Given this list of marker genes MIR4425, STAG3, LSM4, NTRK1, TMEM147-AS1, IGHV3-63, CFAP298-TCP10L, RCOR1, HYAL3, RARA, CCR1, SECISBP2, IVL, SQSTM1, PHF21A, IRAG2, SEC14L1, TRAF4, H2BC7, GABPB2, BAZ1A-AS1, ZNF670, AP4M1, POLA2, SMAP2, ZSCAN12, MAPK14, LMNA, ZNF491, MAPKAP1, ENSG00000255476, LINC00964, ARHGAP31-AS1, RPL30P11, GEM, RC3H2, FAM167A, PPFIBP2, IFIH1, TMPO-AS1, HCG14, TVP23A, LAMTOR4, H2AC12, ANAPC11, FRA10AC1, SNHG9, CEP128, PDZD2, ZNF646, ZNF670-ZNF695, NSUN6, GPR132 (G protein-coupled receptor 132), ERCC6L2, NTN1, PARP2, MIR1245B, BRAF, RNU6-743P, ENSG00000265222, RAB4B, KMT5B, LCN15, ARID2, ANP32B, CNR1, ZNF185, IL16, APOO, ORMDL1, LINC01366, BRWD1, LIMD2, TOR1AIP1 (torsin 1A interacting protein 1), RGS9, GPD2, HELZ2, RPL17P2, ASXL1, RFFL, C12orf57, H1-5, CD69, TRNAU1AP (tRNA selenocysteine 1 associated protein 1), ITGAL, USP3-AS1, C2orf92, CD72, AFF3, TNIP2, TET3, JPH4, POLR3H, FBRS, NALT1, RILPL2 (NCBI Gene Id 196383), NAP1L1, CAB39, SLC66A2, NFKBIA, ATP6V0A1, H2BC26, REV3L, SYT17, BOD1L1, LCN10 (lipocalin 10), RNA5SP493, FUT10, MCM7, VRK1, LNPEP, ARL2BP, MAML2, LRG1, LRRC32, BATF3, FSCN1, NDE1, LZIC, TAFAZZIN, LMNB1, MYEOV, B2M, GABPB1, HMSD, ARHGEF2-AS2, RBM17, FBXW11, ANXA6, ZBTB1, RUNX1, RAD52, LDC1P, KREMEN2, CHD3, H3C4, SFT2D3, AP1G1, DDX31, TEPSIN, RNU4-38P, DOLK, SKIL, SBNO1, PPAN, ZNF295-AS1, PHF24, RIPOR2, THAP9, MIRLET7I, RELA, C16orf46, ATXN1, NIBAN3, MIR3143, ITGB1, NBN, LINC00926, CFLAR, H2AC4, LINC02392, PASK, LINC02579, STAG3L5P-PVRIG2P-PILRB, NANOS3, KLKP1, HSPA4L, CPPED1, ENO3, HMGXB4, WDR11-DT, RHOH, INTS12, RPL11, SBNO2, SHQ1, RHOXF1P3, SLC9A8, CLUAP1, ZCCHC7, RNU7-1, RAI1, BCL9L, ATM, MTMR14, LINC02157, LRP6, G6PD, MIR5700, INO80C, DENND4B, ATXN1L, LINC02100, STAR, TH2LCRR, MSI2, LINC01572, RAP2C-AS1, H2AC7, DIAPH1, H4C13, MDM2, RNVU1-19, SPATA4, RNU5B-4P, MIR27A, ARHGAP26, WRAP53, ARHGAP21, SLC39A13, NEIL2, GSK3B, RNPS1, SGPP2, DVL2, TMEM243, NDUFS7, LINC01588, PLEKHA2, PTEN, LINC00431, CYBA (cytochrome b-245 alpha chain), SEPTIN2, PPAN-P2RY11, B3GNT7, RN7SL121P, RN7SL692P (NCBI Gene Id 106479476), SNX8, GCA, LNCATV, HUWE1, TLCD1, TLNRD1, H3C11, DDHD1-DT, KDM5A, LINC02739, ASNS, RPPH1, H2AC6, LINC01719, NELFB, STRIP1, TFAP4, RBCK1, RNVU1-14, ZC3H12A, CYB561, MYO1C, SNX11, TLR1, MSC-AS1, LINC02174, FCER2, CDKL3, TNFRSF10C, ZNF417, CD70, ECE1, PRPF40B, WNT1, LCOR, ANKRD33B, HORMAD2, MIR497HG, TFEB, LINC00511, ZEB1 (NCBI Gene Id 6935), NEAT1, TRIM13, LINC02090, TG, DOCK2, LINC00384, BIRC3, TMEM248, JUN-DT, PELO, SSTR5-AS1, CTNNB1, CYS1, GABPB1-AS1, TECR, CD58, HSP90AB1, CCDC88A, CALM3, B4GALT6, LACTB, FSD1L, IMMP1LP1, H2BC10, ARSB, KLHL5, IL7R, RABEP1, ADAMTSL4-AS1, RPL10P14, HSPE1-MOB4, STX11, ASMTL, PIK3C2B, SLC12A2-DT, ZNF737, LOXL3, ZNF692, SSBP2, ADGRD1, WDR11, PARP8, PPCDC, USPL1, TNF, H2BC12, ATF4, LINC02611, NOP14-AS1, DUSP2, UNKL, SCARNA2, UBALD2, BCL6B, BTBD19, MMP9, SMIM36, CCDC88C, BAIAP2L1, ISG20, PRKCH, TSGA10 (testis specific 10), LSP1, RPS26, ZNF668, TRAJ47, REL, LINC02960, CD55, CD36, KDM2B, PAFAH2, IKZF2, H4C6, NDUFB7, POLD1, RSL24D1P11, SLC25A11, MEF2C, AMZ2P1, RNU2-63P, ADAM7-AS1, COA1, IKZF1, VRTN, LOXL2-AS1, KLLN, UBE2B, MAK, ENSG00000255491, SYNGR2, GSK3B-DT, PSMA1, SIRT2, GARNL3, TRIP12, ZNF581, ZBTB25, NUP107-DT, ENSG00000273727, MCL1, MYO1G, RNU4-2, CFAP298, H2BC21, APLF, CASC15, CD83, C20orf204, HEXIM2, LZTFL1, OGT, NOTCH1, CD226, TACC1, UHRF1, HMGB1, SP100, TMEM229B, HSPE1, HILPDA, CCDC97, RPS10, KYAT1, AGPAT3, NINJ1, UST-AS2, MIR548AW, H2BC13, H2BC15, RNU4-75P, EPCIP-AS1, CCNL1, H4C5, TNFSF14, THOC1, SH3GL1, TMEM237, ARHGEF12, BAZ1B, APBB3 (amyloid beta precursor protein binding family B member 3), SUN1, UTP3, MTMR9, TNFAIP8, FAM135A, MIR3677HG, SLC25A46, TYW3, SORL1, TTN-AS1, RAB20, TNIP1, CRLF2, AKAP11, GEMIN6, ZNF529, PATL2, RN7SL181P, ZNF221, CCR7, HIP1, SLC25A4, SMPD1, BHLHE40, RNVU1-34, PFN1, CCL15, KDM5C, ENSG00000282849, CR2, CLTC, RND1, QRICH1, UBC, RNVU1-4, ATXN1-AS1, ZNF827, TICAM1, SIPA1L1, RGS20, ADAMTS13 (ADAM metallopeptidase with thrombospondin type 1 motif 13), ZNRF1, PDE4A, CCDC107, MAP4K2, BNIP1, GATAD2A, MYOSLID-AS1 (NCBI Gene Id 101927887), MUC12-AS1, GPR160, ACOXL-AS1, CERS4, PIGV (phosphatidylinositol glycan anchor biosynthesis class V), ADARB2, RBM39, SNORA78, REL-DT, POLI, USP49, RAB14, NFKB2, H3C1, TASL, TTC27, UPF2, LINC02328, MIR5091, LMNB1-DT, HOMER1, TNFAIP3, COX7CP3, LINC00265, H2AC17, ZNF767P, RPS10-NUDT3, H3C7, METTL21A, SNORA70, KSR1, EEIG2, CREM, H4C12, NFE2L2, TBL1X, IDE, LIPT1, CASTOR3P, ERC2 (ELKS/RAB6-interacting/CAST family member 2, NCBI Gene Id 26059), THOC1-DT, POLDIP3, LINC02642, HMG20A, TMOD1, HEXIM1, H2AC8, NUP153-AS1, LRIG1, BANK1, PPP5D1P, EHBP1L1, DNAJB4, MYCBP2, TANK, ITGA4, TSC1, ZNF335, AKR1B15, TPD52L2, SP140, LGALS1, APOLD1, TIAL1, LINC00973, ABCA6, KBTBD6 (NCBI Gene Id 89890), CYP51A1, PALD1, ZFYVE26, DBF4B, ZC3H7B, CCDC77, SNORD3A (small nucleolar RNA, C/D box 3A), KDM2A, APOBEC3H, LINC00938, FBXO31, LINC01152, NAA80, USP32, H2AC20, STK10, IL6R-AS1 (IL6R antisense RNA 1), RNVU1-15, LINC00494, FAT2, MCCC2, GYPC, CALM1, CCDC88B, HEXIM2-AS1, RNVU1-6, PKM, NRG4, ZNF692-DT, DSCAML1, LINC01348, NFKB1, RPL31P29, SLC22A23, ASTL, MIR4273, NOL4L, RELB, DOK2, SHF, ZMIZ1, AP1AR-DT, FBXO48, TRAJ7, MGAT1, CFAP73, RPL7P50, GPR55, HNRNPA1, NDUFAF4, JUN, LINC00881, IL4I1, AKAP13, COL1A1, FOXJ3 (forkhead box J3), CLUH, IST1, CFAP20, ALYREF, SMG5, ATP6V0A2, ERCC6L2-AS1, DHRS13, ENSG00000265246, NRG2, SLC35A4, MS4A1, LINC00877, RPS6KA1, CARD8, TMSB10, RAB30, RNVU1-3, RPS15AP29, ITGB7, PLD3, NCOA3, PRKCD, FYN, VTRNA1-3, H2BC17, HERC4, DDHD1 (NCBI Gene Id 80821), TNFSF4 (TNF superfamily member 4), TSC22D1, ABR-AS1, ZSWIM5, CDC42SE1, LINC01775, H4C1, ZFP36L1, PEAK1, GINM1, NFKBIZ, AP1S3, LINC01353, H2AC13, RN7SL38P, GNA15-DT, ILF2, TESK2, CTBP1-DT, ZPBP2, ENSG00000236403, SRSF7, CCDC57, ABCD4, NEK8 (NIMA related kinase 8), C16orf46-DT, RNVU1-31, PLEK, LRRC8A, RAP2C, PBX2, LINC02320, CTBP1, MAP2K3, ACHE, SMG9, MIR3142HG, RMRP, RHEX, CUL3, PNRC2, ZC3H12C (zinc finger CCCH-type containing 12C), SPRED1, MIR23AHG, ARL5B, ITGA1, TENT4B, FOXP4 (NCBI Gene Id 116113), ATP2C1, H2BC8, RNU4ATAC, GPBP1, TTI2, EP300, METTL15, CORO7, ZFHX3-AS1, TRIM69, CASP8 (NCBI Gene Id 841), ZNF773, RPL10A, BRD2, FOSL1, RNVU1-30, TRIM31, H2BC16P, NEK6, IL32 (interleukin 32), SMG6, MIR4493, MOB3A, KDM3A (lysine demethylase 3A), LINC02384, SNORD13, SC5D, H3C12, CFLAR-AS1, ODAD1, IGFLR1, LINC02132, GABARAP, DEDD, CTSZ, HSPD1, WTAP, MRPL1, FBXL5, RAPGEF1, ADNP, ADAR, HLA-DMB, PLCG2, NAV2, TAPBP, MIR23A, LY86, TCF7, PHIP, PMS1, OXTR, NFATC1, MREG, RGS1, SEPTIN9, BCL2, RPS26P59, RMI2 (RecQ mediated genome instability 2), OAS3, PTPN6, ZNF3, GYS1, PIGX, MIR5194, DIAPH1-AS1, BLK, UBAC2, EPB41L2, BAIAP2, RSF1, RPS6, REPS1, SEMA7A, MIR4674, CREB1, CCNG2, PLAU, CLCN2, MAP1LC3B, PHC3, ENO1, AIM2, GNB2, FNTA, ACOXL, DCLRE1A, ANP32E, LINC03062, MIR6077 (microRNA 6077), CRIP1, SSX2IP, CLASP1, EBI3, CD37, PARP1, FKBP10, RNF167, PRR12, CCL22 (NCBI Gene Id 6367), H2AC10P, CD48, SH3TC1, HILPDA-AS1, KIF13A, SS18, GATAD2B, H2AC25, H2AC16, DENND3-AS1, UTP6, RALGDS, FAM110A, CLEC2D, H4C4, LINC02028, MIR4437, ZBTB5, RNU11, ITFG2-AS1, CXorf58, PDE8A, RPL12P28, CYB561A3, TAF6L, WNT10A (Wnt family member 10A), SLC2A5, CACNA1D, SELENOH, PPP1CC, MIR155HG, ENSG00000215022, FCHO1, LRRCC1, CYP51A1-AS1, CFAP69P1, ZC3H6, CENPU (centromere protein U), H4C3, TMEM79, DUSP22, FBXO36, TMEM18, RASSF4, CCL5, STAT1, HECW2, RPS2, UBB, MTF2, SYT9-AS1, XPO6, POLR2E, NR3C1, GFI1B, TP53, CEP83, LINC01675, SMPD4, TNC, CEP83-DT, H2AC15, ZKSCAN2, RRAD, TBL2, LY9, TTC39A, CRK, ARHGAP45, NCF2, HDAC7, FMNL1, RNU5E-6P, LINC00944, BBC3, IRF5, IL27, OTUD5, TTLL4, ATF7IP, DESI1, THADA, LINC01435, RNVU1-27, RNVU1-26, PTK2, NMNAT1, FAM200B, SIRT1, NFKBID, GSTCD, H2BC18, IL23R, H2BC4, RNU1-119P, PAXBP1, CYP1B1, H4C16, ATXN2L, GSDMB, SNAPC3, MALAT1, STAG3L5P, ALAS1, TATDN3, ZSCAN16-AS1, ADGRG1, SLC12A2, CTTN-DT, MARF1, MIR4710, NUP107, ZFYVE19, KBTBD6-DT (NCBI Gene Id 101929140), DARS1, RAB4B-EGLN2, HLA-DMA, TOB2, CYREN, H2BC9, VPS37B, TMEM277P, ARHGAP31, RNU4-1, PSMC3IP, NFKBIB, CDK12, NUP188, SYTL3, USP53, SRSF5, TNFRSF9, IKZF3, MCFD2, LINC01629, here is a description of the gene set: Human Gene Set: ZNF597_TARGET_GENES species: Homo sapiens Genes containing one or more binding sites for (ZNF597) in their promoter regions (TSS -1000,+100 bp) as identified by GTRD version 20.06 ChIP-seq harmonization. from publication Yevshin I, Sharipov R, Kolmykov S, Kondrakhin Y, Kolpakov F (PMID 30445619)